The following is a description of a gene set: This event has been computationally inferred from an event that has been demonstrated in another species.<p>The inference is based on the homology mapping from PANTHER. Briefly, reactions for which all involved PhysicalEntities (in input, output and catalyst) have a mapped orthologue/paralogue (for complexes at least 75% of components must have a mapping) are inferred to the other species. studied in species Mus musculus Reactome Pathway: NTRK2 activates RAC1 part of: Activated NTRK2 signals through FYN electronically inferred by orthology from the curated human pathway, and this is the list of marker genes: Bdnf, Fyn